The following is a description of a gene set: Human Gene Set: RHODES_UNDIFFERENTIATED_CANCER studied in species Homo sapiens Many studies have used DNA microarrays to identify the gene expression signatures of human cancer, yet the critical features of these often unmanageably large signatures remain elusive. To address this, we developed a statistical method, comparative metaprofiling, which identifies and assesses the intersection of multiple gene expression signatures from a diverse collection of microarray data sets. We collected and analyzed 40 published cancer microarray data sets, comprising 38 million gene expression measurements from >3,700 cancer samples. From this, we characterized a common transcriptional profile that is universally activated in most cancer types relative to the normal tissues from which they arose, likely reflecting essential transcriptional features of neoplastic transformation. In addition, we characterized a transcriptional profile that is commonly activated in various types of undifferentiated cancer, suggesting common molecular mechanisms by which cancer cells progress and avoid differentiation. Finally, we validated these transcriptional profiles on independent data sets. Genes commonly up-regulated in undifferentiated cancer relative to well-differentiated cancer, based on the meta-analysis of the OncoMine gene expression database. from publication Rhodes DR, Yu J, Shanker K, Deshpande N, Varambally R, Ghosh D, Barrette T, Pandey A, Chinnaiyan AM (PMID 15184677), and this is the list of marker genes: TAP1, EZH2, CXCL9, SSBP1, CDK1, RAD21, TOP2A, CDC20, PCNA, MYBL2, NCAPD2, CDKN3, DPM1, H2AZ1, GARS1, TRIP13, PSMD14, RFC4, UBE2S, COL1A2, CEBPG (CCAAT enhancer binding protein gamma), MCM2, RPA3, SLC16A1, KPNA2, CKS2, MCM3, KIF23, NCAPH, PSMB7, CKS1B, CCNB1, BIRC5, MCM6, ILF2, PRDX4, YBX1 (Y-box binding protein 1), PSMD2, HMGB2, GGH, IFI30, GPSM2, NME1, CCT6A, GCLM, PCLAF, H2AX, SLC7A5, POLR2K, ADRM1, CENPA, CDC6, CCNA2, KIF14, CTSL, DLGAP5, TMSB10, MTHFD2, GAS6, TUBB, EIF2S2, MAD2L1, FOXM1, SEC61B, UBE2C, TUBB4A, KIF2C, NUDT1, MELK